The following is a description of a gene set: studied in species Homo sapiens Encephalocele Human Gene Set: HP_ENCEPHALOCELE A neural tube defect characterized by sac-like protrusions of the brain and the membranes that cover it through openings in the skull., and this is the list of marker genes: ESCO2, TCOF1, PAK2, TULP1, ARL13B, NOTCH1, TCTN1, LCA5, CRB1, RDH12, IFT140, ALX3, ARL3, TMEM216, NMNAT1, CSPP1, NODAL, KIAA0586 (KIAA0586), FLNA, TGIF1, CEP290, SMO, POMK, GDF6, POLR1B, LRAT, POMT1, FGF8, C2CD3, MKS1 (NCBI Gene Id 54903), DLL1, FGFR3, GAS1, CBY1, SF3B2, ALX4, CDON, AIPL1, TMEM107, KCNJ13, POLR1D, FREM2 (FRAS1 related extracellular matrix 2), B9D2, PDE6D, TMTC3, VSX1, CRX, SPATA7, DOCK6, TXNDC15, CEP104, GLI2, ZNF423, SUFU, CRIPTO, TCTN2, OFD1, CC2D2A, KIAA0753, ALX1, SIX3, CEP120, FGFR1, MSX2, IMPDH1, AHI1, POLR1C, PIBF1, POMGNT1, CRPPA, DISP1, PCYT1A, FRAS1, TCTN3, TOGARAM1, ZIC2, IQCB1, LAMB1, KATNIP, B9D1 (NCBI Gene Id 27077), TMEM231, RPGRIP1L, COL18A1, LARGE1, RPGRIP1, RBPJ, CYP26B1, EOGT, PTCH1, GMPPB, HSPG2, INPP5E (inositol polyphosphate-5-phosphatase E), STIL, RPE65, TMEM138, ZSWIM6, FLNB, CPLANE1, POMT2, HYLS1, NPHP1, SHH, ARMC9, DLL4 (NCBI Gene Id 54567), TMEM237, USP45, FKTN, FKRP, GUCY2D (guanylate cyclase 2D, retinal), IFT74, HOXD13, TMEM67, TMEM218, TUBB4B, FILIP1, ARHGAP31, GRIP1, B4GAT1, CEP41, RD3, FOXH1